The following is a description of a gene set: Human Gene Set: GOMF_ANGIOTENSIN_RECEPTOR_BINDING Binding to an angiotensin receptor. species: Homo sapiens, and this is the list of marker genes: ZBTB16, EDNRB, ARAP1 (NCBI Gene Id 23290), ARRB2, JAK2, AGT, BDKRB2, ARRB1